The following is a description of a gene set: Any process that modulates the occurrence or rate of T cell death by apoptotic process. studied in species Mus musculus Mouse Gene Set: GOBP_REGULATION_OF_T_CELL_APOPTOTIC_PROCESS, and this is the list of marker genes: Bcl11b, Trp53, St3gal1, Ido1, Rag1, Zc3h8, Cd47, Pdcd1, Tnfrsf4, Rorc, Prkcq, Hif1a, Ada, Serpinb9, Slc46a2 (solute carrier family 46, member 2), Cd274, Jak3, Arg2, Fadd, Pnp, Lgals3, Ripk3, Ccl5, Bmp4, Efna1, Tgfb2 (transforming growth factor, beta 2), Blm, Tnfsf4, Il7r, Bbc3, Vhl, Pdcd7, Siglec1, Wnt5a, Kifap3, Bcl2, Cd27, Adam8, Pip, Casp8, Dock8, Tsc22d3, Nfkbid, P2rx7, Prelid1, Bcl2l11, Bcl3, Gpam, Perp, Prkd2, Ptcra, Gimap8